Given this list of marker genes OTOF (NCBI Gene Id 9381), FOXL1, PRORP, MPDU1, DIAPH3, AIFM1, here is a description of the gene set: Abnormal middle ear reflexes species: Homo sapiens Human Gene Set: HP_ABNORMAL_MIDDLE_EAR_REFLEXES